Given this list of marker genes PNRC1, NRN1, LYRM4, GADD45G, ADGRG6, RPL23, LNX1, RPL11, DYNLT3, TPD52, SLC2A1, RPS23, UQCRB, STC1, TAF1D, RPL8, RPS10, RPL39, INSIG2, SSR3, RPL10A, RPL35, PERP, SMAP1, TATDN1, FBL, MGLL, RPL26, MRPS6, NACA, CD9 (NCBI Gene Id 928), CCL28, RPL30, RPS25, RPL12, PABPC1, RPL27A, RPL23A, TAF12 (TATA-box binding protein associated factor 12), TOB1, TBC1D17, TPT1, RPL28, FBLN2, RPS18, RPS12, RPS3, DSP, LDHA, RPL9, RPS20, RAB4A, IL32, RPL27, YBX3, EBPL, RPL10, RPL31, LOX, RPL22, MT3, IGFBP5, NAP1L1, EGLN1, ATP5MC2, NDUFS4, RPS13, WFDC2, EIF3E, VDAC1, EEF1A1, RPL29, PNMA5, RPL14, COX7C, NEAT1, ECSCR, SNHG32, RACK1, RPS14, KISS1R, RPL19, ASPH, RPL38, RPLP2, LAMC1, CD82, RPL32, CD79B, COMMD6, RPL37, MALAT1, ZFAND1, BRK1, RPS15A, PTTG1IP, here is a description of the gene set: from publication Su Z, Ho JWK, Yau RCH, Lam YL, Shek TWH, Yeung MCF, Chen H, Oreffo ROC, Cheah KSE, Cheung KSC (PMID 38267611) species: Homo sapiens Human Gene Set: SU_HO_CONV_CENT_CHONDROSARCOMA_C4_HIGH_GRADE_CHONDROSARCOMA_1 Major neoplastic cell cluster of High_1 tumors, with markers (e.g., EIF3E, RPL30, RPL32) enriched in ribosome biogenesis and translation GO terms. The transformation of benign lesions to malignant tumours is a crucial aspect of understanding chondrosarcomas, which are malignant cartilage tumours that could develop from benign chondroid lesions. However, the process of malignant transformation for chondroid lesions remains poorly understood, and no reliable markers are available to aid clinical decision-making. To address this issue, we conducted a study analysing 11 primary cartilage tumours and controls using single-cell RNA sequencing. By creating a single-cell atlas, we were able to identify the role of endoplasmic reticulum (ER) stress in the malignant transformation of conventional central chondrosarcomas (CCCS). Our research revealed that lower levels of ER stress promote chondrosarcoma growth in a patient-derived xenograft mouse model, while intensive ER stress reduces primary chondrosarcoma cell viability. Furthermore, we discovered that the NF-?B pathway alleviates ER stress-induced apoptosis during chondrosarcoma progression. Our single-cell signatures and large public data support the use of key ER stress regulators, such as DNA Damage Inducible Transcript 3 (DDIT3; also known as CHOP), as malignant markers for overall patient survival. Ultimately, our study highlights the significant role that ER stress plays in the malignant transformation of cartilaginous tumours and provides a valuable resource for future diagnostic markers and therapeutic strategies.